The following is a description of a gene set: part of: Fructose metabolism species: Homo sapiens The conversion of glucose to fructose via sorbitol was demonstrated by Hers (1960) in the seminal vesicles of sheep, has since been demonstrated as well in human epidydimal tissue, and appears to be the physiological source of the abundant fructose found in seminal fluid. The enzymes of the pathway are likewise abundant in the eye lens and in neurons, where their physiological role is less clear but where they appear to play a central role in diabetic tissue damage. Reactome Pathway: Fructose biosynthesis, and this is the list of marker genes: SORD (NCBI Gene Id 6652), AKR1B1